The following is a description of a gene set: from publication Liberzon A, Birger C, Thorvaldsdóttir H, Ghandi M, Mesirov JP, Tamayo P (PMID 26771021) Human Gene Set: HALLMARK_ANGIOGENESIS species: Homo sapiens Genes up-regulated during formation of blood vessels (angiogenesis)., and this is the list of marker genes: COL3A1, LUM, VCAN, NRP1, SLCO2A1, JAG1, LRPAP1, VAV2, APP, PTK2, VEGFA, COL5A2, PDGFA (platelet derived growth factor subunit A), OLR1, VTN, TIMP1, SPP1, STC1, FSTL1, ITGAV, S100A4, PF4, CXCL6, KCNJ8, POSTN, JAG2, FGFR1, CCND2, LPL, PRG2, THBD, PGLYRP1, APOH, TNFRSF21 (NCBI Gene Id 51323), SERPINA5, MSX1